The following is a description of a gene set: Mouse genes annotated to HALLMARK_HYPOXIA based on orthology mappings provided by the Alliance Genome Consortium from publication Howe DG, Blake JA, Bradford YM, Bult CJ, Calvi BR, Engel SR, Kadin JA, Kaufman TC, Kishore R, Laulederkind SJF, Lewis SE, Moxon SAT, Richardson JE, Smith C (PMID 30224793) Mouse Gene Set: HALLMARK_HYPOXIA studied in species Mus musculus, and this is the list of marker genes: Errfi1, Nagk, Stbd1, Inha, Ccn1, Tgfbi, Sap30, Pdk3, Hdlbp, Ak4, P4ha2, Hk2, Isg20, Gpc4, Ets1, Bgn, Gpc1, Atf3, Eno2, Pgm1, Ugp2, Gbe1, Btg1, Ddit3, B4galnt2, Tnfaip3, Stc1, Angptl4, Tpst2, Chst3, Slc37a4, Klf6, Noct, Eno1b, Hmox1, Tpi1, Serpine1, Tmem45a, Hspa5, Ilvbl, Mt1, Pam, Cdkn1b, Ccn2, Has1, Cdkn1a, F3, Mxi1, Gaa, Adm, Plac8, Pfkp, Igfbp1, Pfkfb3, Ldha, Ccng2, Jun, Pkp1, Prkca, Hs3st1, Brs3, Ccn5, Dpysl4, Il6, Sdc4, Gck, Srpx, Efna1, Vegfa, Cdkn1c, Cited2, Scarb1, Igfbp3, Hk1, Tes, Lxn, Myh9, Pygm, Slc2a5, Plin2, Pfkl, Bcan, Gys1, Hoxb9, Nedd4l, Gapdhs, Efna3, Cavin3, Rora, Sdc2, Pck1, Ppargc1a (NCBI Gene Id 320239), Atp7a, Ncan, Maff, Tktl1, Kdm3a, Anxa2, Bcl2, Tgm2, Pnrc1, Stc2, Pklr, Ero1a, Chst2, Bnip3l, B3galt6, Hexa (NCBI Gene Id 15211), Ndst1, Ndrg1, Siah2, Ldhc, Ext1, Cxcr4, Slc2a3, Akap12, Gpi1, Cav1, Gapdh-ps15, Pdk1, Pdgfb, Lalba, Zfp36, Dcn, Foxo3, Csrp2, Ddit4, Cavin1, Ndst2, Vldlr, Aldoa, Klf7, Xpnpep1, Grhpr, Ppp1r3c, Sult2b1, S100a4 (S100 calcium binding protein A4), Ppp1r15a, Ppfia4, Egfr, Gcnt2, Rragd, Fos, Slc25a1, Glrx, Ier3, Slc2a1, Car12, Fam162a, Adora2b, Ankzf1, Pgf, Cp, Aldoc, Gpc3, Col5a1, Phkg1, Tgfb3, Fbp1, Edn2, Nr3c1, Nfil3, Selenbp1, Ids, Pgam2, Tpd52, Tpbg, Rbpj, Klhl24, Prdx5, Large1, Dtna, Bhlhe40, Tiparp, Ampd3, Lox, Wsb1, Zfp292, Kif5a, Pgm2, Ackr3, Pgk1, Aldob, Slc6a6, Galk1, Map3k1, Kdelr3, Fosl2, Jmjd6, Plaur, P4ha1, Eno3, Mif, Vhl, Dusp1, Pim1, Sdc3, Irs2, Casp6